The following is a description of a gene set: studied in species Homo sapiens Human Gene Set: HP_ABNORMALITY_OF_UPPER_LIMB_JOINT Abnormality of upper limb joint, and this is the list of marker genes: FBXW11, CLIP2, SLC39A8, SCN4A, SMG9, TWIST2, TP63, FGD1, MRAS, HRAS, MET, PSMD12, KMT2B, UROS, HNRNPH1, CYP27A1, GJA1, ZNF407, PITX1, XRCC2, BMPR1B, NEDD4L, POLR3A, ARPC4, LIMK1, CLCF1, CLCN3, FLNB, XYLT1, MYOT, NOG (noggin), TUBB3, COL5A1, B3GALT6, ANTXR2, CYP26B1, SF3B4, PSTPIP1, SLC29A3, STX1A, SIL1, NLRP3, MKS1, PIEZO2, ADAMTS3, B3GLCT, RASA2, NANS, EVC (NCBI Gene Id 7886), TDO2, GNE, SOS1, ESCO2, AIFM1 (NCBI Gene Id 9131, apoptosis inducing factor mitochondria associated 1), CDC6, IFITM5, SPRED2, JAG2, PMP22 (NCBI Gene Id 5376), UNC80, ERCC2, PDE4D, MASP1, MMP2, PIGY, EXT2, ERCC1, MESP2, LFNG, BANF1, BRAF, OPA3, ORC1, MAGEL2, LETM1, GSC, TMEM43, DLG5, LAMA2, HES7, DLL3, CHRNG, MECOM, COL27A1, SCARF2 (scavenger receptor class F member 2), CTBP1, SVIL, MYL11 (myosin light chain 11), JARID2, ASPH (aspartate beta-hydroxylase), ALDH18A1, MAF, B3GAT3, GPKOW, RAB23, BAZ1B, PTPN2, MEG3, AMER1, CHST3, NSD1, SLC35B2, OCRL, OBSL1, RNU4ATAC (NCBI Gene Id 57788), KIF21A, RAF1 (NCBI Gene Id 5894), KRT1, DHX16, ACTA1 (actin alpha 1, skeletal muscle), ADAMTS15, GDF5, TPM2, GTF2I, FILIP1, BMP1, CD96 (CD96 molecule), MUSK, SUZ12, SETD2, RRAS, TGFB2, RERE, GON7, GRB10, CYP2R1, CBFB, PDGFRB, ATR, VPS13B, COL9A3, CLCN5, PQBP1, ECE1, STAT4, PRKAR1A, CCR6, HSPG2, GLDN, FGF16, HDAC8, SOX9, FGFR3, RAB33B, PTPN22, KCNAB2, NUP107, IL2RB, SHOX, LGI4, COG4, LARS2, DLK1, IKBKG, EMD, GNPNAT1, TAF6 (NCBI Gene Id 6878), ZMPSTE24 (zinc metallopeptidase STE24), PRMT7, LTBP3, EFNB1, PHGDH, ANAPC1, EXTL3, KDM5B, COG5, RFC2, DVL1, COL1A1, EZH2, SLC35A3, NDRG1, HOXA13, BPNT2 (NCBI Gene Id 54928), PDPN, SLC34A2, ZDHHC9, WNT4, ZMYM3, H4C9 (NCBI Gene Id 8294), PAX3, ZIC1, MYOD1, RSPO2 (NCBI Gene Id 340419), IL2RA, FERMT1, BCR, EIF2AK3, GABRD, SIK3, SRCAP, COL12A1, SETBP1, NR4A2, MAFB, ADAMTSL2, GTF2IRD1, RMRP, MYH3, CRKL, PRDM16, TONSL, GPC4, LAMB2, ENPP1, ITGA7, SYNE2, MBTPS2, TRPS1, PYCR1, MAP2K2, BRD4, MBTPS1, DYNC2LI1, DYRK1A, HEPHL1, DYSF, MYL2, TBX5, RBM8A, CDT1, CCDC8, FDFT1, SLC26A2, CPT2, TOR1A, NUP133, AKT1, FGF9, PPP1CB, TBR1, COL11A1, TUBA1A, IDUA, PCNT, NEFL, FLNA, GPC6, SELENON, FGFRL1, DVL3, UBAP2L, MAP3K20 (mitogen-activated protein kinase kinase kinase 20), PIGA (NCBI Gene Id 5277), SIN3A, ERI1, EVC2, NALCN, CREBBP, ASXL1, CCN6, GMNN, GTF2IRD2, HACD1, TRPV4, EBP, MAP3K7, SMOC1, ANKRD55, CD247, KIF5A, EIF4A3, FZD2, FBXO11, GNB1, UPF3B, HOXA11, DONSON, ITCH, SALL4, PEX2, COLQ, PLOD1 (procollagen-lysine,2-oxoglutarate 5-dioxygenase 1), TBC1D2B, ABCC6, BHLHA9, IL6ST, SMAD6, RAPSN, APC, GLE1, TFE3, WDR73, SPRTN, PRG4, GLI1, WNT5A, TWIST1, CCDC22, RAB3GAP1, LRP4, PYROXD1, IPO8, SKI, RTL1, EIF4H, PI4KA, SLC10A7, LMBR1, HSPB1, PIK3C2A, MEGF8, COL5A2, TPM3 (tropomyosin 3), ARID1B, KRT14, FLVCR1, IDH2, GLB1, NXN, NONO, CCBE1, TFAP2B, ELN, KRAS, FBN1, DOK7, HNRNPA1, SMC1A, RIPPLY2, GHR, WDR4, AUTS2 (activator of transcription and developmental regulator AUTS2), NIPBL, SLC6A9, SLC39A13, ATP7A, HINT1, CAV1, NPR2 (natriuretic peptide receptor 2), SMAD3, CASZ1, DNAJC30 (NCBI Gene Id 84277), SHH, SLC35D1, NOD2, FBN2, SFRP4, IRF5, TMEM70, LAGE3, BUD23, PRKACA, NF1, FBXO28, MATN3, SNRPB, UBE4B, CSGALNACT1, TGFBR1, SMARCAD1, ERCC5, LMX1B, TMEM222, SYNE1 (spectrin repeat containing nuclear envelope protein 1), SPG11, MECP2, PRKACB, NIN, WDR11, KIAA0319L, PDXK, ROR2, LMNA, TGFBR2, EXOC6B (NCBI Gene Id 23233), FKTN, RPL10, COL6A1, MMP14, FGFR2, CUL7, EP300, OSGEP, TBX2, UBA1, TBX22, LUZP1, CPLX1, PIGV, TBX3, GJB2, NAA10, AFF3, TRIP11, PEX6, COL11A2, MAP2K1, P4HTM, WNT7A, GNB2, HS2ST1, BPTF, TP53RK, GNPTAB, BGN, L1CAM, COMP, KDM5C, B4GALT7, PTPN11, RECQL4, IDH1, BICRA, SPTAN1, MAPK1, MACROH2A1, HLA-DRB1, TMEM270, DHCR24, TRAPPC2, TLK2, TOR1AIP1, NOTCH2, PTRH2, FKBP10, YRDC, STXBP1 (syntaxin binding protein 1), KRT9, RAC3 (NCBI Gene Id 5881), FKBP6, SYT2, KAT6B, CADM3 (NCBI Gene Id 57863), LIFR, RIT1, DDR2 (NCBI Gene Id 4921), ASAH1, FHL1, GALNS, ADAT3, RAD21, TNNT3, CYP27B1, FGFR1, LMBRD2, PEX5, TCF12, EXT1, NCF1, RTTN, LBR, CDC45, PTDSS1, KIDINS220, DMP1, PLEKHG5, COL6A2, CTCF, PTH1R, LEMD3, EMG1, LONP1, CHSY1, GPC3, ASXL3, GDAP1, COG8, SMAD2, KMT2A, SPEN, SMC3, TNNT1, COLEC10, MYL1, IDS, DMD, RSPRY1, CAPN3, POR, SLC34A3, TGDS, PRKCZ, PORCN, COL9A2, CRLF1, SOS2, PLOD3 (procollagen-lysine,2-oxoglutarate 5-dioxygenase 3), KRT16, HK1, ERCC6, CCN2, INF2, SH3PXD2B, COL6A3, ALX3, CUL4B, MED25, RPL26, COL7A1, AEBP1, SHOC2 (NCBI Gene Id 8036), TAF4, MLXIPL, ALG3, UFSP2, PIGL, VPS37D (NCBI Gene Id 171020), TMEM218, KY, ERLIN2, COL9A1, CANT1, COLEC11, ERGIC1, LARGE1, ALG12, CBL, RRAS2, ORC4, HOXD13, POLR3GL, ECEL1, TPRKB, IGHMBP2, HEATR3, APC2, MED12, COL25A1, TGFB3, MEGF10, LZTR1, COL2A1, ANO5, SRY, DYM, GNS, DHODH, MMP23B, METTL27, CTDP1, TBX15, PEX1, ACTG2, NUP88, GNPTG, ALX1, PSMB8, TFAP2A, CNTN1, TNNI2, MMP13, MORC2, SCYL2, KCNK9, ORC6, NRAS, SLC25A46, ABCC9, NSD2, ADGRG6, FBLN1, VDR, TBL2, SIGMAR1, SLC18A3, FAT4, LAMB3, POP1, IHH (Indian hedgehog signaling molecule), CDH3, STAG1, KIF22, TCTN3, PLOD2, SLC35A2, BCOR, MYBPC1, PPP2R3C, GLI3